The following is a description of a gene set: Reactome Pathway: SLC-mediated transport of neurotransmitters part of: SLC-mediated transmembrane transport The SLC6 gene family encodes proteins that mediate neurotransmitter uptake thus terminating a synaptic signal. The proteins mediate transport of GABA (gamma-aminobutyric acid), norepinephrine, dopamine, serotonin, glycine, taurine, L-proline, creatine and betaine. These transporters are mainly present in the CNS and PNS (Chen NH et al, 2004). studied in species Homo sapiens, and this is the list of marker genes: SLC6A15, SLC6A9, SLC17A8 (NCBI Gene Id 64944), SLC6A5, SLC6A20, SLC6A13, SLC25A22, SLC6A1, SLC6A19 (NCBI Gene Id 8062), SLC25A18, SLC6A4, SLC6A14, SLC17A6, SLC6A7, SLC6A2 (NCBI Gene Id 6530), SLC6A11, SLC22A1, SLC22A2, SLC6A3, SLC17A7, SLC32A1